The following is a description of a gene set: The directed movement of phosphate ions into, out of or within a cell, or between cells, by means of some agent such as a transporter or pore. species: Mus musculus Mouse Gene Set: GOBP_PHOSPHATE_ION_TRANSPORT, and this is the list of marker genes: Slc20a1 (solute carrier family 20, member 1), Slc17a4, Fgf23, Ank, Atf4, Slc20a2, Fgfr1, Slc34a2, Slc17a1, Stc2, Slc25a3, Cry2, Ip6k2, Slc37a2, Slc25a10, Cebpb, Sfrp4, Slc17a6, Slc37a4, Slc17a8, Xpr1, Slc34a1, Slc37a1, Fgfr4, Slc17a7, Slc34a3, Ros1, Vdr